The following is a description of a gene set: Mouse Gene Set: MIR_7008_3P species: Mus musculus from publication Chen Y, Wang X (PMID 31504780) Genes predicted to be targets of miRBase v22 microRNA mmu_miR_7008_3p in miRDB v6.0 with MirTarget v4 prediction scores > 80 (high confidence targets)., and this is the list of marker genes: Vopp1, Rimbp2, Bcat1, Sgcz, Lgr4, Brinp3, Slc16a9, Acsl1, Grm1, Hivep1, Vash2, Lcorl, Snx18, Kdm7a, Epha7, Mtmr3, Sertad4, Birc6, Ms4a4a, Lmnb1, Cttnbp2nl, Piezo2, Ncf2, Chm, Gdpd5 (NCBI Gene Id 233552), Bmi1 (Bmi1 polycomb ring finger oncogene), Epha5, Cacna1g, Socs7, Rgl1, Phf6, Olfm3, Lmbr1, Tnc, Pabpc4, Dcbld2, Nup50, Tbc1d8b, Kif3b, Trp53inp1, Rnf19b, Slc22a23, Sfmbt1, Sec61a1, Setbp1, Ube2q2, Irf2, Palld, Pak3, Tub (NCBI Gene Id 22141), Ythdf3, Pi4k2a, Pkn2, Cyp26b1, Stox2 (NCBI Gene Id 71069), Derl2, Ptprn2, Gucy1a2, Oas1e, Ahsa2, Araf, Snx8, Hus1b, Mier3, Grip1, Ei24 (etoposide induced 2.4 mRNA), Kmt2a, Sertad2, Dusp18, Stam2, Tacc1, Gng3, E2f2, Mapk8ip3, Mcc (mutated in colorectal cancers), Arid4b, Ttbk2, Chst8, Fbxo41, Mob1b, Tmem132b, Inhbb, Asic1, Rap1gap, Mmp24, Cxcr2, Herpud2, Sprr2a2, Cyp24a1, Hus1, Pou5f2, Luc7l3, Adgrb3, Pkp4, Atat1, Cacnb4, Galnt13, Fyco1, Hectd2, Sncaip, Slc38a2, Klf9, Phaf1, Fgf12, Ermp1, Pou2f1 (NCBI Gene Id 18986), Dlg2, Zfp935, Tmem151a, Kcnip3, Adcyap1, Bend3, Mpp7, Ark2c, Neurl4, Lypd6b, Plcxd2, Daam1, Dnal1, Jmy (junction-mediating and regulatory protein), Entpd3, Hars2, Ubr3, Tpm4, Zbtb41, Sntb2, Adgrl1, Pold3, Bahd1, Trak1, Rassf2, Pcgf2, AU041133, Scai, Mvb12b, Nmt2, Ppp2r5a, Onecut2, Rnf220, Phc3, Scaf11, Creb1, Mybl1, Nyx, Dolpp1, Ret, Arpp19, Ano6, Brpf3, Sh3glb1, Hcfc1, Fcho2, Snx4, Htra3, Zfp408, B3gat1, Crkl, Ccdc6, Nxt2, Afap1l1, Gba1, Usp32, St18, Larp4b, Zfp236, Nr1d2, Cask, Prkg1, 2310022B05Rik, Ppp1cc, Serinc5, Sost, Tmem25, Gadd45a, Robo3, Glce, Diras2, Lmo7, Dpf1, Wdr48, Sdr42e1, Cdnf, Nrxn1, Frmpd4, Mast4, Myorg, Ptp4a1, Ascl4, Fam3c, Fat3, Paip2, Hecw1, Mtmr1, 2510009E07Rik, Hoxd10, Ankrd13b (ankyrin repeat domain 13b), Ets2, Ankrd44, Kirrel3, Aph1b, Ccdc88a, Sprr2a1, Kctd9, Mcf2, Mknk1, Mtf1, Mysm1, Slc1a2, Ppp4r3b, Arid4a, Tbc1d12, Trim9, Senp1, Vat1, Sar1b, Samd8, Rabep1, Ikzf1, Sox7, Rabgap1l, Kif21b, Ncan, Rlim, Prmt3, Zeb2, Rnf103